Given this list of marker genes Exo1, Exo5, Pld4, Aptx, Dclre1c, Mgme1, Dclre1b (DNA cross-link repair 1B), Pld3, Dclre1a, here is a description of the gene set: Mouse Gene Set: GOMF_5_3_DNA_EXONUCLEASE_ACTIVITY Catalysis of the sequential cleavage of mononucleotides from a free 5' terminus of a DNA molecule. species: Mus musculus